Given this list of marker genes DYNC1I1, PPP1CC, ZWILCH, PSMA2, LBR, TUBB8, CLIP1 (CAP-Gly domain containing linker protein 1), XPO1, ANAPC16, PSMC5, PSMC4, MIS12, NUP155, CHMP7, TUBB8B, PLK1, PPP2CA, PMF1 (NCBI Gene Id 94958), NDEL1, MAD1L1, CCNB2, TAOK1, UBE2D1, CDC20, RAD21, TUBB2A, DYNLL2, BIRC5, NUP93, RAN, UBE2S, RANGAP1, ERCC6L, PSMD8 (NCBI Gene Id 5714), VRK1, ANAPC5, NUP160, IST1, CLASP2, INCENP, BANF1, PPP2R2A, NUP188, TUBA8 (NCBI Gene Id 51807), KNTC1, DYNLL1, PSMD6, LEMD2, TUBB2B, TUBA4A, PSMB4, NDE1, PSMB7, SUMO1, NUP107 (NCBI Gene Id 57122), VRK2, CENPN, UBE2E1, CENPH, TUBA1A, CKAP5, DYNC1H1, NUP35, NUP43, ANAPC11, UBE2C, SMC1A, TMPO, SEH1L, ANAPC10, TUBB3, RPS27A, SPC24, MAPRE1, CHMP4A, CDC23, SPAST, TUBA3E, PSMC3, UBC, ZW10, BUB1, CDC26, SIRT2, DYNC1LI1, RCC2, TUBB4B, ESPL1, PPP2R5E, ADRM1, CHMP2A, ITGB3BP, PSMA3, CHMP4B, PPP2R1B, PPP2CB, KIF18A, NUP54, SMC3, TUBA3C, ANAPC15, NDC1, CDCA5, SGO1, CENPA, ANKLE2, LMNB1, PSMB5, PSMD2, PPP2R5B, CDC27, PSMD12, BUB1B, RPS27, CDK1, SKA1, DYNC1I2, CENPK, CENPE, UBB, PSMC1, TUBA1B, WAPL, CENPQ, CLASP1, CDC16, NUDC, CCNB1, PSMA5, CHMP4C, TNPO1, KIF2C, SGO2, PPP2R1A, NSL1, CENPL, CHMP3, DSN1, PSMB1 (proteasome 20S subunit beta 1), B9D2, PDS5A, CDCA8, CENPT, PAFAH1B1, PSMD11, PSMC6, CHMP2B, UBE2I, ANAPC4, STAG2, CENPU, NUF2, BUB3, NUP133 (nucleoporin 133), NUP58, PSMD14, PSMD1, PSMA4, NUP98, PPP2R5A, LEMD3, CENPM, SKA2, PSMB3, DYNC1LI2, PTTG1, PSMA6, TUBB4A, KNL1, PSMD13, VPS4A, CENPP, ANAPC1, CENPF, PSMC2, SEM1, KIF2A, KIF2B, PSMA1, CENPS, PSMD7, MAD2L1, ZWINT (NCBI Gene Id 11130), TUBAL3 (tubulin alpha like 3), TUBA4B, FBXO5, SPDL1, CHMP6, CENPO, NUP37, TUBA3D, PDS5B, NDC80, PSMA7, TUBB6, STAG1, UBA52, CC2D1B, PSMB6, PSMB2 (NCBI Gene Id 5690), TUBB1, CENPC, POM121, SPC25 (NCBI Gene Id 57405), HDAC8, PPP2R5C, KPNB1, RCC1, LMNA, PSMD3, RANBP2, PPP2R5D, EMD, NUP85, NUP205, AURKB, NUP62, ANAPC7, TUBA1C, CENPI, ANAPC2, SEC13, AHCTF1, here is a description of the gene set: Reactome Pathway: Mitotic Metaphase and Anaphase Metaphase is marked by the formation of the metaphase plate. The metaphase plate is formed when the spindle fibers align the chromosomes along the middle of the cell. Such an organization helps to ensure that later, when the chromosomes are separated, each new nucleus that is formed receives one copy of each chromosome. The movement of the chromosomes is facilitated by a combination of kinetochore movement along the spindle microtubules and through the physical interaction of polar microtubules. studied in species Homo sapiens part of: M Phase